Given this list of marker genes Smurf2, Psmb4, Gnb5, Psmc2, Dvl1, Wnt4, Cltb, Ap2a1, Gngt2, Fzd8, Psma4 (NCBI Gene Id 26441), Psmc1, Wnt11, Gng5, Ctnnb1, Rps27a, Psma3, Prkcg, Gngt1, Pde6b, Gng3, Psmb7, Pde6g, Gng10, Psma5 (proteasome subunit alpha 5), Gng4, Fzd6, Psmd6, Psmc4, Gng11, Gng7, Psmd12, Psma1, Psmc3, Psma2, Psmc5, Psmb5, Rac2, Gnb2, Dvl3, Psmc6, Ppp3r1, Psmd13, Gng8, Tcf7l2, Ap2b1, Plcb3, Ap2m1, Fzd7, Fzd4 (frizzled class receptor 4), Fzd1, Gnao1, Psma7, Psmd1, Pfn1, Gnb3, Wnt5b, Rac3, Smurf1, Arrb2, Prkca (NCBI Gene Id 18750), Psmb6, Dvl2, Ubb, Psma6, Psmd7, Calm1, Fzd2, Nlk, Ap2s1, Wnt1, here is a description of the gene set: part of: Signaling by WNT studied in species Mus musculus Reactome Pathway: Beta-catenin independent WNT signaling electronically inferred by orthology from the curated human pathway This event has been computationally inferred from an event that has been demonstrated in another species.<p>The inference is based on the homology mapping from PANTHER. Briefly, reactions for which all involved PhysicalEntities (in input, output and catalyst) have a mapped orthologue/paralogue (for complexes at least 75% of components must have a mapping) are inferred to the other species.